The following is a description of a gene set: species: Mus musculus Mouse Gene Set: GOBP_POSITIVE_REGULATION_OF_IMMUNOGLOBULIN_PRODUCTION Any process that activates or increases the frequency, rate, or extent of immunoglobulin production., and this is the list of marker genes: Exosc6, Cd40, Il13ra1, Il6, Msh2, Il13, 6030468B19Rik, Kmt5b, Mzb1, Il5, Ephb2, Mlh1, Ptprc, Phb1, Il4ra, Paxip1, Btk, Rif1, Xcl1, Cd37, Nsd2 (NCBI Gene Id 77281), Exosc3, Tnfsf4, Rbp4, Cd86, Cd28, Sash3, Shld1, Mad2l2, Hmces, Pms2, Galnt2 (NCBI Gene Id 14424), Trp53bp1, Kmt5c, Il2, Tlr9, Tnfrsf4, Shld3, Il21, Il10, Hpx, Gpi1, Dnajb9, Il33, Shld2, Tfrc, Il2rg, Tgfb1 (NCBI Gene Id 21803), Tnfsf13, Ifng, Phb2, Xbp1, Tbx21, Il4, Stx4a (NCBI Gene Id 20909), Foxp1, H2-T23, Atad5, Clcf1, Stat6, Pagr1a, Cd27